Given this list of marker genes MXD1, CYMP, ERN1, ZNF610, IFNA8, TP53BP2, ADGRB1, DGKH, C6orf141, SAMD9, TMEM116, KDM6A, DSP, TNFSF15, ETV3, DTX3L, BTN3A1, HPSE, TAP1, SLC29A4, IRF8, PROSER2-AS1, ZSCAN12, NEURL3, ADAMTS1, RYBP, TNF, ZNF267, GPBP1, PLEKHF1, NEXN, EPSTI1, AZIN2, TRIM5, ADAR, FAM111A, TNIP2, GBP5, RPS6KC1, HCG4B, PAG1, NINJ1, C21orf91, NIPAL4, HAPLN3, MASTL, HSPA1L, RFLNA, SP140, BCL2, BEND5, DHX58, CXCL11, CACNA1A, PCGF2, EDN2, RSPH6A, GCSAML, ELOVL7, WTAP (NCBI Gene Id 9589), FXYD6 (NCBI Gene Id 93560), KLKB1, ZNF579, DND1, STAT2, KRT32, PATL2, SCAMP1-AS1, GBP4, TTC21A, FOXF1, SELENOO, HELZ2, CEACAM1 (NCBI Gene Id 634), FGF8, MIS18BP1, SNAPC1, DDIT3, ZC3HAV1, LINC00907, SHFL, LRP2, TGIF1, NLGN3, PMAIP1, AIM2, SLC9A3, MX1, RICTOR, AGAP2, LINC00158, CSRNP1, INTS12, TRAF2, CSRP2, ALPK2, PIGA, SMCHD1, INAFM1, C3orf36, BTG2-DT, CNKSR3, BRIP1 (NCBI Gene Id 83991), USP42, TRIM69, PIDD1, NEMP1, ATP10A, AURKB, GIMAP2, B4GALT5, PLA1A, IRF1, USP11, IL15RA, SECTM1, ZNFX1, CARINH (NCBI Gene Id 441108), TRHDE-AS1, APOA1, HS3ST3B1, SPMAP2, TNFSF10, LINC01003, OAS2, IRF7, CXCL9, SYNPO2, NEDD1, PI4K2B, APOBEC3G, FOSL1, GLCCI1 (glucocorticoid induced 1), SIGLEC1, RBCK1, EZH2, PARP14, CCL5, PPM1K, FAS, RIPOR2, MZF1-AS1, MGC16275, CREB5, ABTB2, IFIH1, RELA, DDX60, LINC01138 (long intergenic non-protein coding RNA 1138), TMCC3, PLS3, CD38, MAK, UBE2Z, FEM1C, NUP210P1, TMEM39A, RNF144A, KDM6B, GTPBP2, HERC6, DNAAF1, TRMT9B, LATS2, PDE4B, IL15, PTGS2, FGFR2, MPV17L, KCNK5, PPP3CC, ASH1L-AS1, ZBTB10, DCP1A, PELI1, ZBTB5 (zinc finger and BTB domain containing 5), RIGI, MIR155HG, DDX60L, RHEBL1 (NCBI Gene Id 121268), NBN, BCL2L14, UBQLNL, ARAP2, NAT8B, EIF2AK3, PGAP1, ASB15, REXO5, MVB12A, NSUN7, IL11, NPC1L1, here is a description of the gene set: studied in species Homo sapiens The dendritic cell (DC) is a master regulator of immune responses. Pathogenic viruses subvert normal immune function in DCs through the expression of immune antagonists. Understanding how these antagonists interact with the host immune system requires knowledge of the underlying genetic regulatory network that operates during an uninhibited antiviral response. In order to isolate and identify this network, we studied DCs infected with Newcastle Disease Virus (NDV), which is able to stimulate innate immunity and DC maturation through activation of RIG-I signaling, but lacks the ability to evade the human interferon response. To analyze this experimental model, we developed a new approach integrating genome-wide expression kinetics and time-dependent promoter analysis. We found that the genetic program underlying the antiviral cell state transition during the first 18-hours post-infection could be explained by a single regulatory network. Gene expression changes were driven by a step-wise multi-factor cascading control mechanism, where the specific transcription factors controlling expression changed over time. Within this network, most individual genes are regulated by multiple factors, indicating robustness against virus-encoded immune evasion genes. In addition to effectively recapitulating current biological knowledge, we predicted, and validated experimentally, antiviral roles for several novel transcription factors. More generally, our results show how a genetic program can be temporally controlled through a single regulatory network to achieve the large-scale genetic reprogramming characteristic of cell state transitions. Genes down-regulated in comparison of control conventional dendritic cells (cDC) at 0 h versus cDCs infected with Newcastle disease virus (NDV) at 18 h. Human Gene Set: GSE18791_CTRL_VS_NEWCASTLE_VIRUS_DC_18H_DN from publication Zaslavsky E, Hershberg U, Seto J, Pham AM, Marquez S, Duke JL, Wetmur JG, Tenoever BR, Sealfon SC, Kleinstein SH (PMID 20164420)